The following is a description of a gene set: Binding to an apolipoprotein, the protein component of a lipoprotein complex. Human Gene Set: GOMF_APOLIPOPROTEIN_BINDING species: Homo sapiens, and this is the list of marker genes: PLG, LPA, LPL, PCSK9, VLDLR (NCBI Gene Id 7436), TREM2, LCAT, SCARB1, MAPT, ABCA1, MTTP, APP, LRP4, LRP1, LRP8, LILRB4, HSPD1, LIPC